The following is a description of a gene set: Human Gene Set: MIR933 Genes predicted to be targets of miRBase v22 microRNA hsa-miR-933 in miRDB v6.0 with MirTarget v4 prediction scores > 80 (high confidence targets). species: Homo sapiens from publication Chen Y, Wang X (PMID 31504780), and this is the list of marker genes: MEF2A, BDNF, F7, RBSN, MAP4K4, TACSTD2